Given this list of marker genes RPPH1, RPP38, POP7, POP5, TRMT10C, POP4, RPP30, HSD17B10, RPP21, RPP25, POP1, RPP14, RPP40, PRORP, here is a description of the gene set: species: Homo sapiens Human Gene Set: GOCC_RIBONUCLEASE_P_COMPLEX A ribonucleoprotein complex that catalyzes cleavage of the leader sequence of precursor tRNAs (pre-tRNAs), generating the mature 5' end of tRNAs.